The following is a description of a gene set: electronically inferred by orthology from the curated human pathway part of: Fcgamma receptor (FCGR) dependent phagocytosis species: Mus musculus Reactome Pathway: Role of phospholipids in phagocytosis This event has been computationally inferred from an event that has been demonstrated in another species.<p>The inference is based on the homology mapping from PANTHER. Briefly, reactions for which all involved PhysicalEntities (in input, output and catalyst) have a mapped orthologue/paralogue (for complexes at least 75% of components must have a mapping) are inferred to the other species., and this is the list of marker genes: Cd3g, Pik3cb, Pld2, Plcg2, Syk, Pld3, Igll1, Pik3r2, Pla2g6